The following is a description of a gene set: studied in species Mus musculus Any process that modulates the frequency, rate or extent of a DNA damage checkpoint. Mouse Gene Set: GOBP_REGULATION_OF_DNA_DAMAGE_CHECKPOINT, and this is the list of marker genes: Map3k20, Ppp1r10 (NCBI Gene Id 66450), Rnaseh2b, Ccar2, Babam2, Fbxo4, Brcc3, Rpa2, Nek1, Etaa1, Cul4a, Rad51, Fem1b, Bard1, Brd4, Chek2, Tti1, Cry1 (NCBI Gene Id 12952), Wdr76, Rfwd3, Brca1, Brca2